The following is a description of a gene set: Human Gene Set: WP_THYROID_HORMONES_PRODUCTION_AND_PERIPHERAL_DOWNSTREAM_SIGNALING_EFFECTS Thyroid hormones production and peripheral downstream signaling effects studied in species Homo sapiens, and this is the list of marker genes: RHEB, TTF1, THRB (NCBI Gene Id 7068), ATF2, ADCY8, SOS1, KDM1A, RPS6KB1 (NCBI Gene Id 6796), TRH (NCBI Gene Id 7200), TBC1D4 (TBC1 domain family member 4), TG, PRKACA, AKT1S1, PIK3CA, PLCB1, SLC5A5, PRDM16, PFKFB2, PPARGC1A, ITGAV, FGF21, SECISBP2L, GRB2, MAP4K5, ADRB3, PPARG, NPPB, MC4R, CASP9, TP53, TSHR (NCBI Gene Id 7253), RPS6, NHSL1, ADCY3, WNT4, FGFR1, MAPK14, UCP1, MDM2, MLST8, NPY, SLC16A2, THRA, POMC, PLIN1, KDM3B, RAF1, TSC1, MAPKAPK3, FRS2, CREB3, RPS6KA6, IYD, AQP7, NPR1, MAP2K1, PNPLA2, ACTL6B, TTF2, AKT3, ZNF516, KLB, MAPK1, SHH, MAFA, RXRA, SRC, TPO, PRKG2, NOTCH1, DUOX2, GSK3B, AGRP, TSHB, DIO1, SLC26A4, MGLL, SLC16A10, ITGB3, SLCO1C1, BAD, FOXO1, TSC2, DUOXA2, CTNNB1, HRAS, PAX8, RPTOR, ITPR2, DIO3, SIRT6, MTOR, DIO2